The following is a description of a gene set: Mouse Gene Set: MIR_206_5P from publication Chen Y, Wang X (PMID 31504780) Genes predicted to be targets of miRBase v22 microRNA mmu_miR_206_5p in miRDB v6.0 with MirTarget v4 prediction scores > 80 (high confidence targets). species: Mus musculus, and this is the list of marker genes: Camsap2, Tnpo1, Mapk8, Rab18, Cpne8, Lig4, Nrip1, Dcaf7, Abi1, Igdcc4, Apbb2, Stxbp5l, Otud4, Eif3a, Camk4, Pcdh7, Lamp3, Rala, Crebrf, B3galt2, Lrp8, Asah2, Or5m3b, Tlk2, Tob2, Satb1, Ubl3, Gpd2, Acvr2a, Neto1, Vat1l, Bcar3 (breast cancer anti-estrogen resistance 3), Cdk19, Fut9, Scn11a, Alcam, Kat7, Usp33, Dcun1d4, Fyn, Tdg, Zmynd8, Nrcam, Adh7, Gpr137c, Etl4, Zfp58, Nlrp9a, Dnm3, Pde4b, Cep126, Kcnip1, Pgrmc2, Fundc2, Slitrk4, Pank3, Nudt9, Fermt2, Lsm14b, Gria4, Tmeff1, Ttl, Hoxc4, Ank3, Epha6 (Eph receptor A6), Thbs2, Ttc28 (NCBI Gene Id 79562), Sbno1, Susd4, Cartpt, Usp48, Phf6, Erc2, Slitrk1, Gm10778, Ankrd40, Slc25a16, Thsd7a, Tent4b, Bnip3, Lgr5, Dnase2b, Hectd2, Hikeshi, Ube2g1, Prkcb, Zpld1, Idua, Cpe, Kdm2b, Mier1, Fat1, Ube2o, Zfp280d, Crebzf, Cdk8, Zfp141, Capza2, Htr3a, Adgrg2, Snph, Eya1, Retreg1, Dpysl2, Nap1l5, Rnf152, Rims2, Sybu, 4921517D22Rik, Saraf, Gpcpd1 (glycerophosphocholine phosphodiesterase 1), Npy6r, Dlg3, Fmod, Prkaa1, Ptchd1, Prom1, Mettl15, Gnal, Itfg1, Togaram1, Top1, Sf3b1, Dlc1, Clip3, Tsc1, Lrp12, Bivm, Rrp1, Zbtb34, Ugt2a3, 1700066M21Rik, Ghr, Pkp2, Ky, Gopc, Bnip3l, Rhox13, Raph1, Sos1 (NCBI Gene Id 70778), Cbfa2t2, Phyhipl (NCBI Gene Id 70911), Nicn1, Ube3a, Spns3, Bend4, Pitx2, Hcar1, Tbx20, Ptpn4, Mecom, Nipbl, Vps37b, Hoxc10, Camta1, Phlpp1, St7, Ptger4, Slc18a2, Bcap29, Mapk6, B3gnt2